Given this list of marker genes KDM6B, NR2C2, SLC6A2, AFF1, SHISAL1, CFAP97D1, KRAS, MAP2K1, SH3TC2, SUFU, C6orf120, MEX3D, TAB2, SEPTIN4, MLIP, SH3YL1, HDGF, IQSEC2, FBXO34 (F-box protein 34), STIM2 (stromal interaction molecule 2), GOLPH3, KIF3B, KIAA0930, CRTC1, EPHA4 (NCBI Gene Id 401031), ZBTB7C, DIAPH1, SCN4B, ATF7, RLF, LINC03040, PDLIM3, PTPRJ, PPP1R9B, OAS2, CAMK2G (NCBI Gene Id 818), FBXO45, OXCT1, SDC3, HPS5, RCN2, STX11, here is a description of the gene set: Genes predicted to be targets of miRBase v22 microRNA hsa-miR-4323 in miRDB v6.0 with MirTarget v4 prediction scores > 80 (high confidence targets). Human Gene Set: MIR4323 species: Homo sapiens from publication Chen Y, Wang X (PMID 31504780)